Given this list of marker genes TCF4, RAF1, ARID1A, GABBR1, CEP295, BUB1, WNT5A, TRIM32, DLX3, IFT52, PQBP1, ATR, TAF4, RBBP8, MAP1B, CEP55, UBE3A, TRPM3, NEDD4L, HERC2, POR, TNNT3, MED13L, KIF7, FAT4, KDM6A, ABL1, SATB2, ORC4, NARS2, NIN, SRCAP, CNOT3, MAN1B1, SMOC1, SPRED2, TFAP2A (transcription factor AP-2 alpha), KIF15, GATA4, ORC6, DLK1, FANCB, KAT8, PACS1, FANCG, SOX4, BBS7, IGF1R, XRCC2, MASP1, MID2, POLA1, SF3B4, SKI, MED25 (mediator complex subunit 25), GDF5, TRIP12, YWHAE, SOX6, NOG, NARS1, NRAS, AFF2, IL11RA, CCDC47, MIA3, MAPK8IP3, AP1G1 (NCBI Gene Id 164), KAT6B, NSD2, BRCA2, PIGW, SMAD4, EBF3, RAD51C, EZH2, CEP152, KCNAB2, SOS2, SIAH1, DEAF1, TBX1, EIF4H, FRA10AC1, LMX1B, MMP23B, FOXP1, SEMA3E, REV3L, BBS10, PGAP3, PHIP, RIT1 (NCBI Gene Id 6016), PITX1, POMP, ERF, CANT1, AHDC1, POLR3A, RFC2, PUF60 (NCBI Gene Id 22827), PLK4, EPB41L1, DPAGT1, NONO, FOXP2 (forkhead box P2), COLEC10, NPR3, NEK1, PTH1R, VPS13B, LUZP1, B3GLCT, FANCI, WDR19, JAG1, BMP4, AUTS2, EXT2, NCAPG2, LMNB2, SMC5, EIF4A3, ALG12, MEGF8, MACROH2A1, MBD5, FGFR3, NCF1, ALDH1A2, CACNA1G, LZTR1, SLC35A1, DONSON (DNA replication fork stabilization factor DONSON), CDKN1C, PWRN1, CDH1, NFIX, GTF2IRD1, ALX3, TRIO, KMT2D, CCNQ, RAB23 (RAB23, member RAS oncogene family), TTC8, FANCE, TMEM270 (NCBI Gene Id 135886), DDX11, BCOR, PRDM16, AGO2, SNX14, SMARCC2, PPP2R1A, SH3PXD2B, SMC1A, CPLANE1, BRAF (B-Raf proto-oncogene, serine/threonine kinase), TRPV4, ELN, GTF2IRD2, SHOX, TRAIP, BAZ1B, MAPRE2, SMARCD1, GATA6, RAD51, RERE, H3-3B, MEG3, PUM1, RAB11B, FLT4, PGAP2, EMG1, WDR4, KDM4B, TMEM231, SIN3A, AKT1, CNOT2, RBM8A, RAI1, DLEC1 (NCBI Gene Id 9940), FBXO11, DVL3, PIEZO2, NSUN2, RTL1, CFAP418, LIG4, FN1, HIC1, TBX4, MECOM, SPRED1, CSGALNACT1, TRRAP, L1CAM, H19, ANKRD11, MAGEL2, TBL2, SCAPER, USP7, LTBP1, SDCCAG8, SIN3B, ERI1, STAG2, MAF, METTL27 (methyltransferase like 27), BUD23 (BUD23 rRNA methyltransferase and ribosome maturation factor), FGFR2, CCDC22, COL27A1, KCNN3, IGF1, FGD1, ROR2, POC1A, HNRNPR, NUP188, CHD8, AMER1, PCGF2, CEP57, FANCM, STAMBP, GTF2I, SMARCB1, INTU, COL11A1, DLX5, CBL, UBE4B, CHD6, SPEN, SNRPN, BCR, ERMARD, KMT2B, GMNN, TMEM147, CLCN3, TELO2, TCF20, NUP85, LEMD3, RHOA, SHANK3, NKX2-5, CDC6, SPOP (speckle type BTB/POZ protein), FGF10, GATA5, SCLT1, CAPRIN1, IFT140, CDC42, CAMSAP1, OFD1, SUZ12, TGDS (NCBI Gene Id 23483), ARID2, CITED2, FAM149B1, FLII, LMNA, PRKACB, PPP1R15B, TRAF7, BUB1B, BUB3, RPL10 (ribosomal protein L10), KIAA0753, MAPK1, KDM5A, ALG3, CHSY1, CLIP2, G6PC3, FLNB, PDPN, FANCL, PIGL (phosphatidylinositol glycan anchor biosynthesis class L), CDC45, MCTP2, SLC29A3, SLC9A7, SMARCA4, DSP, XRCC4, KLF13, RBM10, WDR26, WIPI2, CDH11, IFT172, TPR, NUP107, SOX5, ASCC3, PCDHGC4, CKAP2L, FGFR1, ATP2B1, TMEM216, LZTFL1, TRMT10A, BBS1, MED12, BBS5, TWIST2 (NCBI Gene Id 117581), MAP2K1, DYM, PKDCC, ZMYM2, KDM5C, SLC2A10, RNU4ATAC, POLR1A, TBC1D24, EVC, MECP2, CDT1, POLE, WDR11, PIGY, PACS2, DDX59, MYOD1, CHD7, PAFAH1B1, POGZ, PLXND1, PIK3C2A, FLNA, WDR35, CEP290, PIGH, HOXD13, HUWE1, RFX7, BBIP1, DPF2, MYCN, CSNK2A1, HEATR3, ADAMTS15, NAA10, MKKS, ABCC8, CLCF1, UBR1, BRAT1, BHLHA9, KDR, SMARCE1, HNRNPH1, PAX1, ERCC4, BBS4, BLM, UBE3B, SPECC1L, ADNP, TBX15, BBS2, EVC2, MAP3K7, FLI1, STAG1, IFT27, FANCA, SMC3, SPART, IGF2, RNU4-2, PDE6D, PNPLA6, GABRD, ZC4H2, COG5 (component of oligomeric golgi complex 5), HSPG2, H4C3, TBCK, ZFPM2, BRF1, TCTN3, MYL11, PAICS, HDAC4, UBE2T, WNT7A, KRAS, FANCC, PIGN, GJA8, ATRIP, KIFBP, HMGA2, CHRNA7, SLX4, DNA2, TASP1, PAX3, EP300 (E1A binding protein p300), DHPS, HEPHL1, GPC3, RNF6, SIK3, OBSL1, PIGS, RAD21, KDM1A, GDF1, CDK10, PHGDH, IRX5 (NCBI Gene Id 10265), NUP37, SOX11, PAH, ATG7, IFT74, KCNJ11, CASZ1, ORC1, FGF16, CCDC8, PRKCZ, MRAS, WWOX, NEXMIF, BLTP1, BBS9, DVL1, QRICH1, CRKL, AMMECR1, SNRPB, RASA2, EFNB1, NAA20, SPRTN, PTPN11, BPTF, IFT122, PIK3CD, HOXA13, NXN, ATP6V1B2, RSPRY1, EHMT1, RAC3, ARID1B, VPS37D, ZNF292, GNB2, NSMF, TRIP13, HNRNPK, FZD2 (NCBI Gene Id 2535), YY1AP1, TBX5 (T-box transcription factor 5), RAB3GAP2, WDPCP, IFT43, SSR4, CTCF, ZFX, PCNT, PALB2, TRAPPC9, MKS1, BRIP1, DCHS1, SMARCA2, ALX1, KPTN, PHF21A, UBAP2L, ARL6, FANCF, PLAG1, COL2A1, SNORD116-1, ESCO2, BBS12, BMP2, NKX2-6, KCTD1, IHH, WNK3, HDAC8, NPR2, EIF4A2 (eukaryotic translation initiation factor 4A2), IQSEC2, FANCD2, KMT2A, NIPBL, ODC1, ZNF462, KCNJ5, PRR12, KDM6B, PIGO, XYLT1, ATRX, CENPE, SALL1, RB1, PIGV, CUL4B, ACVR1, GJA1, PWAR1, KCNK4, RALA, TAF6, NPHP1, MITF, SNORD115-1, CD96, RFWD3, KNSTRN, DACT1, FKBP6, KCNJ2, TWIST1, RAB18, TRPS1, COG8, TFAP2B, RRAS, PIK3R1, TGFBR2, CEP19, HOXA11, STX1A, DDX3X, GPC4, GRB10 (growth factor receptor bound protein 10), CUL7, BRCA1, EXOSC5, ZNF668, RRAS2, UBA2, RNF216, BRD4 (bromodomain containing 4), RUNX2, ITCH, BMPR1B, MLXIPL, DNAJC30, OGT, CCNK, MAD2L2, TOPORS, CREBBP, MKRN3, MTRR, CCDC32, FIG4, SLC26A2, TP63, SOS1, NPAP1, JUP, LIMK1, MEF2C, CDK13, GJA5, INPP5E, here is a description of the gene set: An angulation of a digit at an interphalangeal joint in the plane of the palm (finger) or sole (toe). Human Gene Set: HP_CLINODACTYLY Clinodactyly species: Homo sapiens